Given this list of marker genes TFR2, BAG2, F12, S100A10, NLRC4, ANXA2, PLGRKT, TNP1, ADAM8, TNP2, GSN, MELTF, ASTL, KLKB1, NKD2, MYH9, SRC, CLEC3B, CCBE1, ENO1, MMP14, RHBDD1, HPN, CNTN2, ANGPTL8, SPON1, here is a description of the gene set: Human Gene Set: GOBP_POSITIVE_REGULATION_OF_PROTEIN_MATURATION Any process that activates or increases the frequency, rate or extent of protein maturation. studied in species Homo sapiens